Given this list of marker genes MT-ND1, ESAM, MT-ND6, MT-ND2, MT-ND4 (mitochondrially encoded NADH:ubiquinone oxidoreductase core subunit 4), NEK1, MT-CYB, DNAJC30, MT-ATP6, MT-CO3 (mitochondrially encoded cytochrome c oxidase III), MT-ND5, MT-ND4L, SELENOI, here is a description of the gene set: Retinal arterial tortuosity species: Homo sapiens The presence of an increased number of twists and turns of the retinal artery. Human Gene Set: HP_RETINAL_ARTERIAL_TORTUOSITY